The following is a description of a gene set: Mouse Gene Set: GOBP_REGULATION_OF_EXTRINSIC_APOPTOTIC_SIGNALING_PATHWAY studied in species Mus musculus Any process that modulates the frequency, rate or extent of extrinsic apoptotic signaling pathway., and this is the list of marker genes: Faim2, Igf1, Hyal2, Ripk1, G0s2, Fasl, Il1b, Pmaip1, Traf1, Pycard, Itgav, Raf1, Mapk7, Icam1, Ppp1ca, Htra2, Pml, Jak3, Sgk3, Hmox1 (NCBI Gene Id 27970), Gfral, Pak5, Rnf34, Gper1, Tnfsf10, Sh3rf1, Bcl2l1, Inhba, Acvr1 (activin A receptor, type 1), Il19, Phip (pleckstrin homology domain interacting protein), Fem1b (NCBI Gene Id 14155), Rbck1, Gclm, Hgf, Csf2, Bmpr1b, Pea15a, Ar, Fga, Fadd, D1Pas1, Tnfsf12, Fgfr1, Gsk3b, Gas1, Scg2, Fgf10, Tnfsf15, Tnfrsf12a, Bmp4, Faiml, Brca1 (breast cancer 1, early onset), Eya4, Tgfbr1, Cflar, Ptprc, Gpx1, Faf1, Cd40lg, Tnfrsf4, Dedd2, Gdnf (glial cell line derived neurotrophic factor), Ppp2r1b, Skil, Stx4a, Unc5b, Thbs1, Bcl2l10, Il7 (NCBI Gene Id 319295), Traf2, Deptor, Sp100, Sfrp2, Itga6, Htt, Bcl10, Gstp1, Bid, Tnfaip3, Srpx, Siglec1, Tnfsf14, Src, Eya2, Tnfsf11 (NCBI Gene Id 21943), Bcl2, Tgfb2, Gstp3, Trps1, Stk4, Madd, Cav1, Vegfa, Tnf, Dbh, Peli3, App, Tnfrsf22, Ctnna1, Tlr4, Gstp2, Runx3 (NCBI Gene Id 56483), Nrp1, Gstp-ps, Stk3, Atf3, Hmgb2, Map2k5, Cyld, Itprip, Nf1, Dab2, Acsl5, Ret, Rps6kb1, Zmynd11, Tmbim1, Prdx2, Klf4, Mal, Cx3cl1, Rffl, Nrg1, Faim, Mcl1, Wwox, Ltb, Fgb, Bcl2l14, Sfrp1, Siah2, Stradb (STE20-related kinase adaptor beta), Casp8, Yap1 (yes-associated protein 1), Snai2, Lgals3, Gclc, Lta, Gata1, Col2a1, Il4, Nol3, Pdia3, Serpine1, Tnfsf4, Itm2c (NCBI Gene Id 98594), Psme3, Dapk3, Psen2 (presenilin 2), Zswim2, Fyn, Birc6, Tert, Tlr6, Agap2, Hspa1b, Rela, Fgg, Fcmr, Agtr2, Ppp2r1a (NCBI Gene Id 76182), Rb1cc1, Tmc8, Tcf7l2, Agt, Pak2, Cttn, Eya3, Gsdma3, Tnfrsf23, Grina, Lmna, Park7, Eya1, Ltbr, Ddx3x